The following is a description of a gene set: Unwinding of a DNA helix, driven by ATP hydrolysis. studied in species Homo sapiens Human Gene Set: GOMF_DNA_HELICASE_ACTIVITY, and this is the list of marker genes: DSCC1, DHX9, CHD1L, MCM9 (NCBI Gene Id 54844), HELB, RUVBL2, CHD8, DNA2, RAD51, POLQ, SETX, DDX12P, MRE11, WRNIP1, RFC3, ERCC2, HELQ, ZGRF1 (zinc finger GRF-type containing 1), RUVBL1, WRN, DHX30, RECQL4 (RecQ like helicase 4), MCM2, DDX3X, ERCC3 (NCBI Gene Id 2071), RFC2, NAV2, MCM4, CHTF8, FBH1, TWNK, RFC4, RTEL1 (regulator of telomere elongation helicase 1), MCM5, BRIP1, DDX11L8, MCM6, MCM3, BLM, G3BP1, ASCC3, MCM7, UPF1, XRCC6, SUPV3L1, MCM8, FANCM (NCBI Gene Id 57697), ZRANB3, RFC5, RAD54B, ERCC6, HFM1, XRCC5, RECQL5, RECQL, RAD50, DHX36, PIF1, CHTF18, IGHMBP2, DDX11